The following is a description of a gene set: Genes in the cancer module 418. Human Gene Set: MODULE_418 species: Homo sapiens, and this is the list of marker genes: MEF2C, RALGAPB, SELE, RAP1GAP, KRT14, SYT8, MSI1, ACP5, GDA, RHOU, MREG, ABCC2, GCA, SEMA3B, ZNRF1, SCGB1A1, MXI1 (NCBI Gene Id 4601), PCDH1, NHSL1, MX2, RNF167, BEX4, H2BC7, SLC10A1, PKIB, UNC13A, BAZ2B, SECTM1, DPYSL5, UFSP2 (UFM1 specific peptidase 2), MAPK8IP2 (mitogen-activated protein kinase 8 interacting protein 2), KRT19, PACS2 (phosphofurin acidic cluster sorting protein 2), NRCAM, NPL, CSTA, SPON1, AVPI1, TACSTD2, CD200, HLA-DQB1, NKD2, ABCC6, IFI44, ANXA9, DYNC2H1, MMP25 (NCBI Gene Id 82110), CP, KYNU, INPP5F, RUNX3, SYT13, GPRASP2 (NCBI Gene Id 114928), KRT17, TPSAB1, SMIM3, TIE1, COLEC12, ASPN, SMPD3